Given this list of marker genes Arsa, Aldoa, Ly6k, Rab3a, Vdac2, Ttll5, Sec23ip, Spata33, Crkl, Adam24, Ap3b1 (NCBI Gene Id 97864), Spata22, Iftap, Park7, Cct5, 4930451I11Rik (RIKEN cDNA 4930451I11 gene), Cct6a, C2cd6, Ints13, Spink1, Hvcn1, Ube2q1, H3f3b, Fndc3a, Ccdc159, Hoxd11, Ube3a, Klk14, Plcb1, Spam1, Kmt2c, Map7, Rnase10, Pithd1, Tsx, Nectin2, Cfap52, Zan, Adam32, Zp3, Tnp2, Cd9, Trim36, Npr2, Lyzl4, Dcst1, Sptbn4, Tssk4, Trpc7, Wdr48, Leat1, Cct2, Tdrkh, Catsper1, Rabl2, Tdrd12, Folr2, Ybx3, Mael, Spag1, Ash1l, Garin1b, Adam18, Prss55, Cfap69, Ovgp1, Odad3, Trpc2, Itga3, Camk2b, Lrrc46 (NCBI Gene Id 69297), Adam3, Rimbp3, Fbxo24, Garin5a, Hspa1l, Mfge8, Acrbp, Bsph1, Fsip1, Bcl2l1, Frey1, Syt6, Sppl2c, Poc1b, Tex15, Ovch2, Slc22a16, Drc1, Cntln, Ppp3r2, T, Kdm5b, Col6a1, Nlrp5, Pmis2, Ppp3cc, Stxbp1, Pla2g10, Fcrl5, Cacna1h, Zp1, Foxl2, Plcd4, Slx, Aaas, Rec8 (REC8 meiotic recombination protein), Stx2, Adam5, Cfap119, Abhd2, Iqcf1, Acr, Zpbp2, Wbp2nl, Cylc2, Prnd, Iqch, Adam1b, Hoxd9, Tarbp2, Spink13, Cct8, Garin4, Cct4, Spaca5, Plb1, Trpc3, Wdr54, Cd46, H1f6, Spata46, Dcst2, Tpst2, Fam170a, Kcnu1, Ubap2l, Tex101, Duox2, Nr2f2, Tmprss12, Hoxd10, Glipr1l1, Iqcn, Spaca7, Myh9, Ccdc136, Plcz1, Garin5b, Cfap57, Spaca6, Cfap70, Spaca4, Adam1a, Hexb, Spesp1, Rims1, Unc13b, Zp3r, Zfx, Prdm9, Lrriq1, Lhfpl2, Ccno, Eqtn, Meiob, Sly, Cct3, Astl, Bbs1, Gnpda1, Cecr2, Snu13, Prss37, Lcn6, Bax, Nell2, Umodl1, Antxr2, Dkkl1, Smad4, Zp2, Ehmt2, Lyzl6, Garin3, Hps1, Bbof1, Folr1, Atp1a4, Semg1, Tmem81, Cast (calpastatin), Wt1, Itgav, Prdm14, Cylc1, Syt8, Ooep, Insl6, B4galt1, Sycp2, Glra1, Smcp, Rad21l, Tmem95, Catsper2, Hoxa10, Izumo1r, Plat, Atp8b3, Trpc6, Klhl10, Spaca3 (sperm acrosome associated 3), Llcfc1, Hoxa11, Fam170b, Hoxa9, Itpr1, Actl9, Pcsk4, Lypd4, Ar, Npm2, Tex11, Mcidas, Ccdc87, Spa17, Glrb, Crisp4, Izumo1, Hyal3, Tdrd9 (tudor domain containing 9), Apob, Slc9b1, Irag2, Wee2, Cct7 (NCBI Gene Id 12468), Adcy3, Nectin3, Tcp1, Spink2, Hyal5, Adam2, Zpbp, Actl7a (actin-like 7a), Slxl1, Ccdc146, Clgn, Spag8, Fetub, Gmnc, Garin2, Pkdrej, Hspa1b, Slirp, H3f3a, Clic4, Gm773, here is a description of the gene set: species: Mus musculus Mouse Gene Set: GOBP_FERTILIZATION The union of gametes of opposite sexes during the process of sexual reproduction to form a zygote. It involves the fusion of the gametic nuclei (karyogamy) and cytoplasm (plasmogamy).